Given this list of marker genes Galm, Gm1110, Gale, Glb1l2, Galt, Pgm1, Glb1l, Glb1l3, Glb1, B4galt1, Chst1, Galk1, Galk2, here is a description of the gene set: The chemical reactions and pathways involving galactose, the aldohexose galacto-hexose. D-galactose is widely distributed in combined form in plants, animals and microorganisms as a constituent of oligo- and polysaccharides; it also occurs in galactolipids and as its glucoside in lactose and melibiose. Mouse Gene Set: GOBP_GALACTOSE_METABOLIC_PROCESS species: Mus musculus